The following is a description of a gene set: species: Homo sapiens Glucose metabolism Human Gene Set: REACTOME_GLUCOSE_METABOLISM, and this is the list of marker genes: SEH1L, G6PC3, NUP58 (nucleoporin 58), HKDC1, NUP160, PFKFB1, RANBP2, GPI, NUP210, NUP54, GAPDHS, PPP2CB, AAAS, BPGM, NUP37, PPP2R1B, PKLR, PC, PCK2, PFKFB3, NUP85, HK3, NUP62, NUP98, PGK1, ALDOA, SLC37A4, NUP107, ENO2, POM121C, NUP155 (nucleoporin 155), PFKP, G6PC1, NUP93, NUP35, PKM (NCBI Gene Id 8127), PGM2L1, NUP88, PPP2R1A, PPP2R5D, PGK2, PFKL, PGAM2, GNPDA1, PRKACB, GCKR, ENO1, NUP188, PRKACG, NUP205, GAPDH, NUP133, GCK, RAE1, ENO3, NUP43 (nucleoporin 43), SEC13 (SEC13 homolog, nuclear pore and COPII coat complex component), NUP42, TPR, NUP153, PPP2CA, PFKFB2, NUP50, TPI1, HK2, NUP214, ALDOB, G6PC2, NDC1, FBP2, POM121, ADPGK, SLC37A2, PCK1, HK1, FBP1, PRKACA, GNPDA2, PFKFB4, PGAM1, SLC37A1, ALDOC (aldolase, fructose-bisphosphate C), ENO4, PFKM